Given this list of marker genes TICAM1 (TIR domain containing adaptor molecule 1), TLR3, TRAF3 (TNF receptor associated factor 3), here is a description of the gene set: TNF Receptor Associated Factor 3 (TRAF3) is a cytoplasmic adaptor protein utilized by the tumor necrosis factor receptor superfamily and toll-like receptors (TLRs). TRAF3 deficiency is thought to mimic the previously reported TLR3 deficiency in terms of susceptibility to herpes simplex virus type 1 (HSV1) encephalitis (HSE) via impaired TLR3-mediated immunity against HSV1 infection of central nervous system (CNS) (Pérez de Diego R et al. 2010; Guo Y et al. 2011). Reactome Pathway: TRAF3 deficiency - HSE species: Homo sapiens part of: Diseases associated with the TLR signaling cascade